The following is a description of a gene set: species: Mus musculus Mouse Gene Set: MIR_5616_5P Genes predicted to be targets of miRBase v22 microRNA mmu_miR_5616_5p in miRDB v6.0 with MirTarget v4 prediction scores > 80 (high confidence targets). from publication Chen Y, Wang X (PMID 31504780), and this is the list of marker genes: Kbtbd11, Ebf1, Bicd1, Sema3g, Zpbp, Pde3a, Celf4, Pcnt, Lhfpl6, Jade1, Ppp1r3e, Herpud2, Alg10b, Slc6a1, Dapp1, Pdcl, Lrpprc, Zscan25 (NCBI Gene Id 666311), Pnoc, Zfp606, Usp34, Fbn2, Adgra2, Bnc2, Sgip1, Fgfr3, Cox16, Btn2a2, Csf2rb2, Aplf, Ric1, 1700025G04Rik, AI429214, Fzd1, Kcnb1, Slc8a1, Wdr77, Top1, Srp72, Igfbp5 (insulin-like growth factor binding protein 5), Golga4, Mapre1, Nalf1, Zfp521, Ppfia2, Ptgr1, Dgkg, Cmya5, Fbxl14, Zfp874b, Tmem167, Lin52, Mapk10, Dio2, Dr1, Fam240b, Jag1, Stam, Emc3, Cldn8, Gria3, Gcm1, Tmem248, Samd4, Otulinl, Rfx7, Pabpn1, Acss3, Zfp329, Esyt3, Zfp772, Vcl, Zpld1, Ythdc2, Pknox2, Gucy1a2, Atp8b2, Zcchc24, Bhlhe22, Pomt2, Ntng1, Hk2, Zic2, Cnr1, Rab7, Slc25a53, Zfand3, Septin4 (NCBI Gene Id 18952), Ddr2, Sh3pxd2a (SH3 and PX domains 2A), Grik3, Igtp, Entrep3, Vwc2l, Mlx, Tfdp1, Cdh2, Stxbp5l, Ednrb, Agap1, Sec14l4, Ppm1l, Isl1, Igsf9b, Dpysl2, Rbfox1, Pradc1, Fam210a, Rbm41, Enpp2, Ndrg2, Ces2e, Six4, Eef1a2, Lpgat1, Shoc2, Gabrg1, Sdc3, Traf3, I830077J02Rik, Asb3, Mdn1, Marchf3, Dao, Ss18, Adal, Brinp1, Mob1b, Cdk19, Hmgxb4, Pde12, Atmin, Arsj, Pigg, Fam20b, Zfp768, Fzd4, Cdh11, Ppp1r1c, Dcaf5, Sema5a, Lama5, Sohlh1, Ankrd17, Gtf2a1, Rnf32, Pcdhb3, Synj2bp, Vav2, Cxxc4, Emd, Fst, Kdm4c, Ankrd28, Sall1, Olfm3 (NCBI Gene Id 229759), Chst2, S2bpcox16, Treml2 (NCBI Gene Id 328833), Sim1, Ankrd69, Lrp4 (NCBI Gene Id 277398), Foxj2, Ptprb, Pikfyve, Ildr2, Mmp16, Frmd4b, Kcmf1, Dlgap2, Plekha3, Celsr2, Maco1, Etv1, Adamts18, Arhgef33, Taok1, Rap2c, St8sia4, Fam43a, Doc2a, Kcnd3, Gsk3b, Erbb4, Plxdc2, Alcam, Igf2bp2, Klhl6, Cplx4, Cntrl, Utrn, Ankrd44, Nrg3, Usp38, Osbpl9, Tfdp2, Sgtb, Dnmt3a, Shprh, Runx1t1, Adam22, Tmem183a, Zfp944, Rnf13, Rap1gds1, Med13l, Rbfox2, Smad5, Zfp324, Vps54, Mbnl1, Slc43a1, Gbp4, Cntn3, Sgk3, Tspan2, Slc10a4-ps, Cdkn2d, Niban1, Pdzk1, Psd3